The following is a description of a gene set: studied in species Homo sapiens Any process that stops, prevents, or reduces the frequency, rate or extent of translational elongation. Human Gene Set: GOBP_NEGATIVE_REGULATION_OF_TRANSLATIONAL_ELONGATION, and this is the list of marker genes: RACK1, CPEB2, SHFL, SRP9, CPEB3, EIF4A3